Given this list of marker genes Pla2g4a, Mif, Tnfsf11, Il1a (NCBI Gene Id 16175), Pla2g3, Il1b, Mapk9, Oxt, Acsl4, P2rx7, Edn1, Tnfrsf11a, Atp5pf, P2ry2, Ptges, Pla2g10, Map2k6, here is a description of the gene set: Any process that modulates the frequency, rate or extent of the regulated release of a prostaglandin from a cell. studied in species Mus musculus Mouse Gene Set: GOBP_REGULATION_OF_PROSTAGLANDIN_SECRETION